The following is a description of a gene set: This event has been computationally inferred from an event that has been demonstrated in another species.<p>The inference is based on the homology mapping from PANTHER. Briefly, reactions for which all involved PhysicalEntities (in input, output and catalyst) have a mapped orthologue/paralogue (for complexes at least 75% of components must have a mapping) are inferred to the other species. part of: Antigen processing-Cross presentation studied in species Mus musculus Reactome Pathway: Cross-presentation of soluble exogenous antigens (endosomes) electronically inferred by orthology from the curated human pathway, and this is the list of marker genes: Psma7, Psma1, Psmb10, Psme2, Psmc3, Psmc1, Psmd6 (NCBI Gene Id 66413), Psmd7, Psmc5, Psmc4, Cd207, Psme1, Psma3, Psma5, Psmb6, Psma6, Psmd12, Psma2, Psmb9, Psmb5, Psmd13, Psmd1, Psma4, Psmc2, Psmb4 (NCBI Gene Id 19172), Psmb7 (NCBI Gene Id 19177), Mrc2, Psmc6, Psmb8